The following is a description of a gene set: The directed movement of ornithine, 2,5-diaminopentanoic acid, into, out of or within a cell, or between cells, by means of some agent such as a transporter or pore. Mouse Gene Set: GOBP_ORNITHINE_TRANSPORT species: Mus musculus, and this is the list of marker genes: Slc7a3, Slc25a2, Slc7a2 (solute carrier family 7 (cationic amino acid transporter, y+ system), member 2), Slc25a29, Slc7a6, Slc25a15, Slc7a1